The following is a description of a gene set: Mouse Gene Set: TABULA_MURIS_SENIS_MESENTERIC_ADIPOSE_TISSUE_ENDOTHELIAL_CELL_AGEING from publication Tabula Muris Consortium (PMID 32669714) studied in species Mus musculus, and this is the list of marker genes: Arhgdia, Tmem119, Tut7, Tomm6, Dpysl2, Kmt2b, Cavin1, Pdzd8, Rbm26, Lyz2, Lrrc8a, Gsn, Afdn, Rnf44, Mcrs1, H2-Aa, Ccdc80, Cd74, Selenom, Cd151, Mxd4, Sox18, Marf1, Sod1, Thbd, Ddit4, Cldn5, Klf13, Rhoc, Jund, Hexb, Kdm6b, Col18a1 (collagen, type XVIII, alpha 1), Rpl5, Tnfsf12, Nsd3, Pcnp, Pfn1, Gnb1, Ccdc85b (NCBI Gene Id 240514), Msn, Gstm1, Ywhae, Parvb, Arfrp1, Rab1b, Cfl1, Dcn, Ptms, Crim1, Dpt, Fus, Pdcd4, Tmsb10, Dhrs3, Rnpepl1, Smco4, Dusp3, Mgp, Drap1, Hnrnpl, Bsg, H2-Ab1 (NCBI Gene Id 406212), Tle5, Olfml3, Ushbp1, Anp32a, Selenow, Ybx1, Msx1, Rpl13a, Pfkfb3, Tcf7l1, Gpx3